The following is a description of a gene set: Binding to cadherin, a type I membrane protein involved in cell adhesion. Mouse Gene Set: GOMF_CADHERIN_BINDING species: Mus musculus, and this is the list of marker genes: Rtn4, Cdh6, Cdh18, Pkp1, Ctnna3, Ctnna1, Cdh7, Cdh26, Cdh20 (NCBI Gene Id 23836), Cdhr18, Cdh4, Ctnnd2, Cdh17, Pkp2, Acvr1, Cdh13, Ptpro, Cdh19, Cdk5r1, Cdh2, Fxyd5, Ctnna2, Cdh8, Cdh15, Ptprj, Dchs1, Ptprt, Ndrg1, Cdh10, Cdh24, Obscn, Cnga3, Olfm4, Mmp24, Cdh23, Ptpn11, Ppp1ca, Cd46, Ptprh, Prom1, P2rx4, Akap5, Neo1, Epcam, Cdh22, Cdh11, Ank3, Psen1, Jup, Cdh9, Nos2, Cdh1, Nos3, Cdh12, Ctnnd1, Pkp3, Numb, Ptprb, Cdh5, Ctnnal1, Tbc1d2, Bmpr2, Ptprm (NCBI Gene Id 19274), Trpc4, Ctnnb1, Cdh3, Cd2ap, Kdr, Arvcf, Pkp4